The following is a description of a gene set: Metagene derived from the post-Immune checkpoint blockade treated samples. Significance of the post-ICB sample metagenes was not discussed in the study. Mouse Gene Set: ZENG_GU_POST_ICB_METAGENE_39 Most patients with cancer are refractory to immune checkpoint blockade (ICB) therapy, and proper patient stratification remains an open question. Primary patient data suffer from high heterogeneity, low accessibility, and lack of proper controls. In contrast, syngeneic mouse tumor models enable controlled experiments with ICB treatments. Using transcriptomic and experimental variables from >700 ICB-treated/control syngeneic mouse tumors, developed a machine learning framework to model tumor immunity and identify factors influencing ICB response. Projected on human immunotherapy trial data, found that the model can predict clinical ICB response. further applied the model to predicting ICB-responsive/resistant cancer types in The Cancer Genome Atlas, which agreed well with existing clinical reports. species: Mus musculus from publication Zeng Z, Gu SS, Wong CJ, Yang L, Ouardaoui N, Li D, Zhang W, Brown M, Liu XS (PMID 36240281), and this is the list of marker genes: Krt78, Tmigd1, Krtdap, Cpa4, Nkpd1, Cym, Ifi27l2b, Dapl1, Dsc3, Pglyrp4, Abca12, Mmrn1, Krt1, Bpifc, Ly6m, Rdh1, Ly6g6c, Fa2h, Adgrf2, Slc6a20a, Pinlyp, Tprg1, Epha4, Ephx3, Card14, Ces2c, Alox12e (NCBI Gene Id 11685), Hephl1 (NCBI Gene Id 244698), Serpina12, Tchh (NCBI Gene Id 99681), Ceacam19, Clca3a2, Awat2, Sprr2a2 (small proline-rich protein 2A2), Mab21l4, Gprin2, Wnt3, Psapl1, Phf24, Efna3, Atp10b, Lipm, Myrf, Cyp4f14, Asprv1 (NCBI Gene Id 67855), Krt16, Gucy2c, Wfdc1, Ptk6, Pnpla1, Krt10, Mrgprx2, Pla2g4e, Adcy2, Dchs2, Slurp1, Tmprss13, Spink5, Pla2g4f, Ache, Cdh9, Krt5, Cidea, Aqp3 (aquaporin 3), Cyp2j9, Skint6, Rnf225, Tenm2, Mep1a, Adgrf4, Pou2f3, Cyp4f39, Psors1c2, Fam25a, Crct1, Trim15, Degs2, Rec8, Sbsn, Nccrp1, Elovl3, Anxa13, Tnmd, Gal3st1, Rdh12, Susd2, Cyp2b10, Npas2, Aldh3b2, Paqr5, Ccl20, Atp8b5, Serpinb12, H2-Eb2, Krt6a, Dmkn, Tm4sf4, Gcnt3, Klk9, Ppp2r2c, Aldh3b3, Pdzd2, S1pr5, Cysrt1, Apba2, Scd3, Krt79, Xkr9, Trpv3, Alox12b, Gpld1, Gpr17, Elovl4, Adtrp, Ace2, Ttc22, Slc5a1 (solute carrier family 5 (sodium/glucose cotransporter), member 1), Far2, Tmem45b, Prox1 (prospero homeobox 1), Scel (NCBI Gene Id 80682), Pdzk1, Srcin1, Pof1b, Serpinb1c, Coch, Lipk, Pou3f1, Mroh6, Calml3, Mc5r, Baiap3, Xkrx, Gsdma, Foxn1, Abcg8, Sdr42e1, Il31ra, Serpinb5, Corin, Elmod1, Aox4, Scube2, Klk7 (NCBI Gene Id 23993), Fgf22, Cdh17, Tmprss11f (transmembrane protease, serine 11f), Smco3, Ankrd35, Mkrn2os, C7, Exph5, Edn3, Onecut2, Kcnk7, Cyp3a13, Kctd4, Fat3, Ugt1a1, B4galnt2, Ttc16, Ackr2, Cdsn, Sult5a1, Muc13, Krt15, Aloxe3, Bbox1, Npc1l1, Slc45a3, Ano9, Tgm3, Grhl1, Sec14l4, Spag17, Tpsg1, Xkr4, Serpinb7, Gfra3, Chit1, Tmprss4, Cldn18, Abcg4, Serpinb6c, Il22ra1, BC016579, Tgm5, Tacstd2, Slc34a2, Lgr5, Krt36, Evpl, Gask1a, Rapgefl1, Dsg3, Nkain4, Cdhr2, Capns2, Muc3a